The following is a description of a gene set: Genes positively differentially expressed in cell type: γδ T cell upon treatment with cytokine: IL-33 in mouse lymph nodes in vivo. studied in species Mus musculus from publication Cui A, Huang T, Li S, Ma A, Pérez JL, Sander C, Keskin DB, Wu CJ, Fraenkel E, Hacohen N (PMID 38057668) Cytokines mediate cell-cell communication in the immune system and represent important therapeutic targets. A myriad of studies have highlighted their central role in immune function, yet we lack a global view of the cellular responses of each immune cell type to each cytokine. To address this gap, the authors created the Immune Dictionary, a compendium of single-cell transcriptomic profiles of more than 17 immune cell types in response to each of 86 cytokines (>1,400 cytokine-cell type combinations) in mouse lymph nodes in vivo. A cytokine-centric view of the dictionary revealed that most cytokines induce highly cell-type-specific responses. For example, the inflammatory cytokine interleukin-1β induces distinct gene programmes in almost every cell type. A cell-type-centric view of the dictionary identified more than 66 cytokine-driven cellular polarization states across immune cell types, including previously uncharacterized states such as an interleukin-18-induced polyfunctional natural killer cell state. Mouse Gene Set: CUI_T_CELL_GD_IL33_RESPONSE_UP, and this is the list of marker genes: Phgdh, Rnf213, Rtp4, Oas3, Ifit1, Ifi27l2a (NCBI Gene Id 76933), Lgals3bp, Psme2, Xaf1, Bst2, Cd74, Ifit3, Zbp1 (Z-DNA binding protein 1)